Given this list of marker genes Slc27a6, Slc27a4, Apod, Lcn9, Slc27a1, Lcn12, here is a description of the gene set: Mouse Gene Set: REACTOME_TRANSPORT_OF_FATTY_ACIDS species: Mus musculus Transport of fatty acids